The following is a description of a gene set: Any anomaly in the function of thrombocytes. Abnormal platelet function Human Gene Set: HP_ABNORMAL_PLATELET_FUNCTION studied in species Homo sapiens, and this is the list of marker genes: WAS, HPS6, BLOC1S6 (NCBI Gene Id 26258), FLI1, GNAS (GNAS complex locus), TUBB1, AP3B1, MGAT2, KCNJ1, NBEAL2, THPO, GP1BB, GP6, HPS5, ITGA2B, MYH9, PTPN11, LCP2, BLOC1S5, TPM4, EPHB2, MRAS, IKZF5, GP1BA, SOS2, NRAS, ITGB3, KRAS, WIPF1, RUNX1, GATA1, PLAU (plasminogen activator, urokinase), TBXA2R, BLOC1S3, SPRED2, HPS3, SLC35A1, LYST, SOS1, GFI1B, CBL, SAMD9L, RASA2, ABCG8, RASGRP2, SH2B3, P2RY12, RIT1, CISD2, CALR, LZTR1, DIAPH1, VWF, DTNBP1, ACTN1, RRAS2, GP9, RRAS, GUCY1A1, RAF1, PLA2G4A